Given this list of marker genes CLIP1, TUBB4B, TUBA3E, TUBA4A, CDH1, CALM1, TUBA1A, TUBA1C, TUBB8B (tubulin beta 8B), TUBA3D, TUBB2A, CTNNB1, TUBB4A, IQGAP3, RAC1, IQGAP1, TUBA4B, TUBB6, TUBAL3, TUBB1, TUBB2B, TUBA1B, TUBB8, IQGAP2, TUBA8, ACTB, TUBA3C, ACTG1, TUBB3, CTNNA1, MEN1, CDC42, here is a description of the gene set: IQGAPs constitute a family of scaffolding proteins characterized by a calponin homology (CH) domain, a polyproline binding region (WW domain), a tandem of four IQ (isoleucine and glutamine-rich) repeats and a RAS GTPase-activating protein-related domain (GRD). Three IQGAPs have been identified in human, IQGAP1, IQGAP2 and IQGAP3. The best characterized is IQGAP1 and over 90 proteins have been reported to bind to it. IQGAPs integrate multiple signaling pathways and coordinate a large variety of cellular activities. IQGAP proteins IQGAP1, IQGAP2 and IQGAP3, bind activated RHO GTPases RAC1 and CDC42 via their GRD and stabilize them in their GTP-bound state. IQGAPs bind F-actin filaments via the CH domain and modulate cell shape and motility through regulation of G-actin/F-actin equilibrium. Binding of IQGAPs to F-actin is inhibited by calmodulin binding to the IQ repeats. Based on IQGAP1 studies, IQGAPs presumably function as homodimers.<p>IQGAP1 is involved in the regulation of adherens junctions through its interaction with E-cadherin (CDH1) and catenins (CTTNB1 and CTTNA1). IQGAP1 contributes to cell polarity and lamellipodia formation through its interaction with microtubules. part of: RHO GTPase Effectors Reactome Pathway: RHO GTPases activate IQGAPs studied in species Homo sapiens